The following is a description of a gene set: Delayed ossification of carpal bones Ossification of carpal bones occurs later than age-adjusted norms. Human Gene Set: HP_DELAYED_OSSIFICATION_OF_CARPAL_BONES studied in species Homo sapiens, and this is the list of marker genes: EXTL3, RMRP, PTH1R, IHH, HOXA13, PIGV, MATN3, BGN, EXOC6B, TRPV4, TONSL, UFSP2, COL2A1, LONP1, MBTPS1, TRIP11, CBFB